Given this list of marker genes PPP1CB, STK11, KLHL10, CBX2, ARID1B, HPSE2, MYH11, SEC24C, ALDH1A2, GATA1, DNM2, IFT172, ALG12, GP1BB, TACR3, ODC1, EZH2 (NCBI Gene Id 392834), FSHB, IER3IP1, SAMD9, SOX2, CAMSAP1, CLIC2, MKRN3, ACTA2, MED11, CITED2, UBA1, PWAR1, MECP2, AR (androgen receptor), INSL3, POLR1B, GRIA2, ZSWIM7, FKRP, MYMK, STT3A, POLR1D, NEDD4L, EVC, BBS2, PEX11B, CDC42, EHMT1, GBA2, JAM3, LARP7, SPATA22, B4GALT7, GFM2, CSPP1, NDN, PDE4D, KCNQ1OT1, ESS2, NR5A1, TFAP2A, ZDHHC9, ZBTB20, KMT2D, MED13L, ADNP, MAP3K1 (NCBI Gene Id 4214), RASA2, TTC8, KCNAB2, TRIM32, AP1S2, HNRNPK, SOX4, PAICS (phosphoribosylaminoimidazole carboxylase and phosphoribosylaminoimidazolesuccinocarboxamide synthase), TAF6, CCR1, WRAP53, PWRN1, PTCH1, SOS2, WNT5A, CATIP, FDFT1, NIPBL, LZTR1, B3GLCT, FUZ, POLR1C, MADD, DKC1, DPH2, NAA10, ARNT2, MSH5, TEX14, EWSR1, CTC1, AUTS2, ERCC2, ACBD6, SRCAP, TBCE, SRY, POR, ADAT3, IFT27, MCM5, CDKN1C, H19 (H19, imprinted maternally expressed transcript), SIX6, GLE1, BCOR, MDFIC, BRCA1, TOE1, RPL10L, KDM1A, TXNRD2, PIEZO1 (piezo type mechanosensitive ion channel component 1 (Er blood group)), DNAJC30, NPHP1, BUD23, DHX37, NRAS, PDE11A, B9D1, PTDSS1, ZPR1, CHD8, ZFPM2, INPPL1, RAD51, MAPK1, PORCN, SLC25A10, CDC73, RAB3GAP1, SRA1, TBCD, XPC, CUL4B, DDX59, MAP2K1, STAG1, PHACTR1, VEGFC, LMBR1, ATM, CTDP1, KEAP1, FAM111A, KAT5, EDEM3, SRD5A2, DNMT3A, CTCF, COLEC11 (NCBI Gene Id 78989), STX1A, PIGL, TERB1, ESAM, GDF6, RNF135, WNK3, ANAPC1, ACTB, DVL1, SHOC1, FTO (FTO alpha-ketoglutarate dependent dioxygenase), DAZ2, SPEN, GPC3, PHGDH, KLRC4, SLC16A2, SYCE1, GJA1, FAM149B1 (family with sequence similarity 149 member B1), GDF1, KIF21A, NALCN (sodium leak channel, non-selective), DAZ4, CCBE1, CLCN4, FBLN1, HNRNPR, JMJD1C, BDNF, HFE, TIAM1, ROR2, SPECC1L, CPE, PIGG, SLC30A7, CD96, IL1RAPL1, WDR37, FANCD2, TAC3, IFT80, MYLK, SLC39A4, FGF10, OCA2, AKR1C4, ERCC1, ESCO2, GPC4, MAB21L1, DICER1, CEP290, IRX5, DNAJC21, ZMYM2, BBS7, PBX1, KMT2E, SLC26A2, DGCR8, UBR1, SMARCE1, TARS1, DTYMK, GSC, CDH2, TERT, IFT74, POMGNT1, DAG1, PEX2, ARVCF, HS6ST1, LETM1, EP300, DYNC2I2, ZEB2, ALX4, KIF7, RTEL1, FGD1, FBXO43, MUSK, CHD6, CLIP2, HYLS1, ACTG2, DNA2, DPP9, LYN, LAS1L, HMGA2, TMEM231, WRN, PEX10, KAT6A, ORC4, MASP1, POLR1A, MOGS (NCBI Gene Id 7841), LIG4, CCDC141, PEX19, TBL2, TBX4, BMP4, SMC1A, PIGA, LZTFL1, RBMX, RTTN, STAT4, BRWD3, PPP1R12A, PACS2, DPYSL5, LMOD1 (NCBI Gene Id 25802), SLC18A3, PROKR2, UFD1, EVC2, PDPN, WWOX, WNT7B, MAMLD1, PHF8, HIRA, NPM1, MAP2K2, SLC34A2, FANCC, GRB10, GRIA3, TCTN2, CLP1, TRRAP, GJA5, AARS1, POMK, HSPG2, TXNDC15, CBL, TNRC6B, SLC25A24, SGPL1, TBX22 (NCBI Gene Id 50945), CFAP418, CCDC28B, DYRK1A, CYP19A1, COL4A1, CHD7, IL12A-AS1, PEX26, TCF4, BMP2, IL17RD, NPAP1, PARN, DLX4, C4A, MEIOB, ARX, HDAC8, NFIB (nuclear factor I B), NXN, CCDC32, CKAP2L, DLL3, SATB2, TBX1, GRIP1, MKS1, CYP11B1, LMX1B, DSE, VAC14, RORA, COL3A1, APC2, ERCC8, RBM10, STRA6, CCDC22, BBS9, DDX3Y, FEZF1, SOX5, DMXL2, C2CD3, COLEC10, XRCC4, PAX6, NSD2, FGFR1, PLVAP, PRKACA, KDSR, TRIP13, VPS13B, FGFR2, MESP2, XPA, PRIM1, EIF5A, SPAG17, ROBO1, NOTCH2, WNT3, ATP6V0A2, ATR, ARID1A, HSD17B3 (NCBI Gene Id 3293), ORC1, GALT, RPGRIP1, GLI1, VPS35L, EED, JAG1, REST, RNF113A, GRIN2B, TINF2, BRD4, NANOS1, GNRHR, CDC6, EMG1, PYCR1, DHODH, TCTN1, HYMAI, POLR3K, MCM8, VPS50, HOXC13, POLD1, SCAPER, GJB4, KDM5B, NDNF, IRF6, MAD2L2, PPFIBP1, BUB1B, PIGS, TGDS, MAF, DNAH10, TCOF1, FLNB, CFTR, TBL1XR1, CHRM3, PQBP1, TEX11, CC2D2A (coiled-coil and C2 domain containing 2A), SLC19A2, MYRF, PAX7, TPM2, DOK7, CRPPA (NCBI Gene Id 730683), PIK3C2A, SOX10, FMR1, LHCGR, HIBCH, DMRT1, TOPORS, OCRL, MAGEL2, KMT2A, DDB2, PUM1, FKTN, STT3B, H4C5, POLR3A, POLE, WDR35, CAMK2A, AHDC1, SUZ12, TUBA1A, HOXD13, ZNF462, BICRA, RLIM, STAG3, FLG, FBXO11, NSUN2, NSMF, RAC3, GPR161, RNF212, NNT, TDRD9, LIMK1, GTF2I, CT55, BRCC3, UBAC2, VANGL1, DPF2, DLK1, SMS, PEX1, FANCL (NCBI Gene Id 55120), DACT1, ABCD4, DMPK, ERCC5, HCCS, IGBP1, MOV10L1, THSD1, ALK, PMM2, TMEM70, ARL6, CDC42BPB, BRAF, PTCH2, SOX11, GABRD, ABL1, WNT7A, HDAC4, CPLX1, PSMC1, SCLT1, SEMA3A, POU6F2, GNB2, PRKAR1A, ATN1, CYB5A, DAZ3, PROP1, LHX1, PEX6, LHB, MAPRE2, OTUD5 (NCBI Gene Id 55593), TAF4, GJB3, SNRPN, SOHLH1, FXR1, BRCA2, POLG, DCAF17, MINPP1, FANCI, TMEM107, MRAP, IL12A, DUSP6, PDE6D, MTOR, METTL27, RAD21, KLHL15, GJC2, PSMD12, FBN1, MDM2, ALG8, TMEM94, PIK3CA, MMP23B, MED12, SPRY4, GTF2E2, PEX3, B4GAT1, AGA, DYNC2I1, DHCR7, NKX2-5, ARCN1 (NCBI Gene Id 372), NUP88, TMEM270, TERB2, SMARCA2, POLA1, WDPCP, TSPY1, PROK2, PRKCZ, CHRNG, FOCAD, G6PC3, CYP11A1, STAC3, SMARCB1, SMARCAL1, CCDC34, HLA-B, PEX16, TSPYL1 (NCBI Gene Id 7259), ANK1, PNLDC1, GATA5, HRAS, RSPO1, OTUD6B, USP7, TTC5, ERCC4, TWIST2, MRAS, CWC27, GNRH1, SMOC1, SETD5, YY1, MC2R, LSS, FILIP1, CARS1, CLCN3, ANKLE2, KRAS, RFWD3, FANCF, GNAS, CDKN2A, TRIM28, WBP4, AMHR2, TMEM216, KDR, DYNC2H1, UBE2A, RNU4ATAC, SDCCAG8 (NCBI Gene Id 10806), PHIP, FKBP6, DEPDC5, TMEM67, RAC1, IGF2, GTF2IRD1, COMT (NCBI Gene Id 1312), LEP, LUZP1, H1-4, TP53, AFF4, NELFA, PTPN11, RAPSN, SLC35D1, LARGE1 (LARGE xylosyl- and glucuronyltransferase 1), PLAG1, NDP, FANCE, ERCC3, SMCHD1, BBIP1, CEP120, ATP6V1E1, EXT2, CASZ1, MPLKIP, MCTP2, FREM2, SETD1A, PNPLA6, RSPO2 (NCBI Gene Id 340419), POMT2, TERC, UBE4B, BIN1, MBTPS2, SOX9, SALL1 (NCBI Gene Id 6299), LFNG, FARS2, NR0B1, GATA4, TEX15, FANCA, BRIP1, ADAMTS15, RAF1, RTL1, ORC6, WDR11, CDKN1B, RYR1, NHP2, ZFX, NDUFB11, ARID2, TP63, DNHD1, OGT, HBA2, CDK8, PRDM13, VAMP7, SKI, SMARCC2, UPF3B, CDC45, RXYLT1, PIGN (phosphatidylinositol glycan anchor biosynthesis class N), HNRNPH1 (NCBI Gene Id 3187), CEP112, FZD2, TMEM237, KIAA0753, TNFRSF1A, ASH1L, FBXW7, SIM1, CUL7, KISS1R, MTM1, DHH (NCBI Gene Id 791256), WDR62, ZMYM3, SEC23A, RERE, ZSWIM6, COG5, RARB, TOGARAM1 (NCBI Gene Id 23116), SMAD4, PLAGL1, KDM5C, KCNQ1, PAX2, RIPPLY2, PTPRF, FOXA2, ITPR1, GMPPB, IL10 (NCBI Gene Id 3586), ATAD3A, MAP3K7, RAB18, SIAH1, BBS5, POGZ, EIF4H, NOTCH3, MEFV, CHEK2, TUBB, SMC3, PEX14 (peroxisomal biogenesis factor 14), USB1, PEX5, HS2ST1, AMH, CDON, TASP1, NKX2-6, FGFRL1, LEPR, FGF17, UBR7 (NCBI Gene Id 55148), SNORD115-1, ZMIZ1, PEX12, RIN2, BBS12, EBP, FGFR3, GPC6, RPL10 (NCBI Gene Id 88324), PHF6, ABCB7, EFNB1, DGCR6, CHD4, POU3F3, DVL3, SPRED2, LHX4, LMNA, OPHN1, RRAS2, SLC29A3, KDM3B, TAF4B, RPGRIP1L, TRIP4, KISS1, NF1, KMT5B, TCF12, HERC2, NOP10, MYOD1, NDUFB7, CTBP1, OFD1, RIPK4 (receptor interacting serine/threonine kinase 4), SYCP3, ERCC6, HES7, CDT1, RRAS, H4C9, NAF1, MEGF8, SEMA3E, POU1F1, RAD51C, ZNF699, ALKBH8, DAZ1, MBD5, NKAP, RBMY1A1, FGF8, PRMT7, GMNN, MECOM, IL23R, XRCC2, BAZ1B, LONP1, SOX18, RAB23, GATA6, AXL, ASXL3, RIT1, FIG4, DPAGT1, ANKRD11, B3GALNT2, IFNGR1, GLI2, AKT1, DIS3L2 (DIS3 like 3'-5' exoribonuclease 2), MRPS28, CCDC174, FLRT3, SOS1, TSR2, TLR4, HBA1, SLX4, GK, MYL11, TBCK, BBS4, PEX13, WFS1, ANGPT2, FRAS1, WT1, NONO, TRPM3, ATRX, FANCG, SOX3, SMARCA4, BBS10, DDX3X, SETBP1, CDH11, FBXL4, MEG3, CILK1, DHDDS, LRIG2, SHOC2, KDM6B, PRDM16, PTEN, NHLH2, UQCC2, PALB2, PRKACB, HESX1, TYMS, ERAP1, ATP6V1A, RECQL4, ADAMTS3, SMARCD1 (SWI/SNF related, matrix associated, actin dependent regulator of chromatin, subfamily d, member 1), AEBP1, VPS37D, B9D2, TCTN3, OTX2, MID1, ELN, SNORD116-1, CPLANE1 (NCBI Gene Id 84157), LMNB2, FAT4, BRF1, POMGNT2, ALMS1, FLI1, STAR, XYLT2, EIF2S3, CREBBP (CREB binding protein), HNF1B, SIN3A, BLM, NSD1, BBS1, KANSL1, FLT4, PACS1, CEP19, MKKS, FANCM, PPP1R15B, MTMR14, BMP6, TSHB, COX7B, ADARB1, DNAJC19, CHST14, PIEZO2, SYNE1, RAB3GAP2, FLNA, CEP152, CDCA7, UBE2T, MYH3, DDX6, EBF3, NFIX, PDHA2, GTF2IRD2, TWIST1, KAT6B, PRPS1, SUFU, DYNC2LI1, HUWE1, FANCB (FA complementation group B), KDM6A, RFC2, ALDH18A1, KCNJ6, NCF1, STXBP1, COG1, ANOS1, HPRT1 (hypoxanthine phosphoribosyltransferase 1), FAS, POMT1 (protein O-mannosyltransferase 1), STS, GLI3, GTF2H5, TBX3, DGCR2, THOC2, RREB1, AKR1C2, SCYL2, HSD3B2, USP9Y, MYF6, CYP17A1, DCC, ZMYND15, TBC1D20, MYT1L, here is a description of the gene set: Human Gene Set: HP_ABNORMAL_TESTIS_MORPHOLOGY studied in species Homo sapiens Abnormal testis morphology An anomaly of the testicle (the male gonad).